Given this list of marker genes Sh3rf3, Stox2, Pik3r3, Zfp518a, Tnrc6c, Vstm2b, Magi2, Epgn, Ebf2, Usp33, Eif4g2 (eukaryotic translation initiation factor 4, gamma 2), Mphosph9 (M-phase phosphoprotein 9), Rap2c, Rnase2a, Map3k12, Marchf2, Pcdha10, Memo1, Myh11 (NCBI Gene Id 99850), Eif4a2, Mllt6, Npepl1, Fhip1a, Pik3cb, Prune2, Atp10a, Get3, Macf1, Arrdc3, Rnf167, Ephb3, Foxp1, Hbp1, Ccdc88a, Nrk, Rap1b, Adipor2, Hhip, Dsel, Sin3b, Hecw2, Kcna4, Snx17, Bcl2l11, Pcdhac2, Klhl20, Acsl1, Arc, Ark2n, Pcdha4 (protocadherin alpha 4), Dpysl5, Coq10b, Otud1, Or10d5j, Igf2r, Mycl, Cand1, Slc24a3, Phf12, Ndfip2, Wnt7b, Dnai1, Ano1, Cdk19, Bend3, Pde5a (NCBI Gene Id 242202), Rsbn1l, Tsc1, Bmpr2, Asap2, Prrt3, Pgm2l1, Slmap, Adss2, Bhlhe23, Edaradd, Fndc3a, Camsap1, Atg16l1, Tbrg4, Fastk, Ppp2r3d, Wdr26, Gpr155, Atf2, Stk35, Pdf, Nbeal2, Klf13, Mtcl2, Fam83g, Hipk3, Dipk1a, Itch, Mbnl2, Skida1, Ell2, Fosl1, Tet3, Akr1c14, Zfp91, Fras1, Rap1a (NCBI Gene Id 99734), Rhob, Adgrl2, Rnf216 (NCBI Gene Id 97262, ring finger protein 216), Rimkla, Tbc1d12, Srsf6, Ankrd29, Prickle2, Zfp563, Cast, Spryd3, Slc35f1, Ccm2, Cnot6l, Pcdha7, Ttc9, C87436, Prr5l, Fbxo8, Adamts7, Mef2a (myocyte enhancer factor 2A), Rfx4, Skil, Smarca2, Pcdhac1, Plaa, Sel1l3, Abhd17c, Klf10, Chl1, Fbxo32, Wdfy3, Vps37a, Kbtbd8, Impdh1 (NCBI Gene Id 320849), Spire1, Usp32, Txlng, Eeig1, Tnfaip3, Fut9, Sybu, Hic1, Ino80, Ube2d3, Cntfr, Klhl42, Mapk1, Rufy3, Gigyf1, Zfp965, Clip1, Pmepa1, Tab3, Atxn1, Abca1, Prkaa1, Phf13, Atxn7, Gtf2a1, Ccnl1, B4galt5, Sipa1l1, Pcdha9, Mbd6, Ddx3x, Gpcpd1 (glycerophosphocholine phosphodiesterase 1), Zfp973, Pcdha8, Sbf2, Wasl, Tshz3, Tgif1, Sdc1, Rnf11, Vps4b (vacuolar protein sorting 4B), Cnot4, Zdhhc18, Grsf1, Dtna, Gm11437, Fam83d, Trim33, Mastl, Arap2, Tfcp2l1, Phtf2, Mapk6, Zbtb10 (zinc finger and BTB domain containing 10), Pdik1l, Qki, Ddx3y, Pou4f1, Zfp827, Sgk1 (NCBI Gene Id 20393, serum/glucocorticoid regulated kinase 1), Zmynd11, Agbl3, Cnksr2 (NCBI Gene Id 245684), Med26, Mdm4, Cacna1c, Kcne2, Slc5a7, Chic1, Ube2a, B230219D22Rik, Elovl5, Cldn34c1, Castor2, Tgm3, Zfp654, Mpped2, Fmr1, Scn1b, Mylip, Adcy7, Csmd1, Lsm12, Ankib1, Adcy1, F3, Ddhd2, Ldoc1, Arhgap11a, Cep170, Acbd5, Ccdc126 (NCBI Gene Id 58912), Garem1, Etl4, Pnrc1, Lin9, Slc4a7, Rbms3, Btf3l4, Plxnc1, Dock10, Mier3, Dnaaf9, Pcdha5, Wnk1, Miga2 (NCBI Gene Id 99073), Sowahb, Cacul1 (CDK2 associated, cullin domain 1), Med13, Gtf2h1, Mycn (NCBI Gene Id 18109), Ice2, Slc6a8, Arfip1, Hbs1l, Igfbp3, Npas3, Kpna6, Fam162a, Armc8, Plxna4, Id2, Stat2, Sema4c, Brwd3, Dnajc24 (DnaJ heat shock protein family (Hsp40) member C24), Hnrnpul2, Llgl2, Zbtb18, Lrig1, Sulf1, Zfand5, Arfgef1, Tmem47, Rbbp8, Appl1, Dock4, S1pr1, Car8, Zfp992, Patl1, Syt1, Asxl2, Vti1a, Pcdha2, Rbms1, Pknox1, Usp8, Wbp1l, Lrch1, Retreg1, Mdfic, Robo2, Dgke, Suz12, Card10, Pitx1, Bnc2, Npas2, Eogt, Shank1, Tbk1, Slc31a2 (solute carrier family 31, member 2), Ldaf1, Slc9a6, Arhgap21, Pou3f2, Siva1, Klf9, Nufip2, Raf1, Zfp521, Sox6, Mtmr10, Cblb, Lrp2, Atl2, Zfp385b, Rgl1 (NCBI Gene Id 19731), Tspan2, Taf4, Dicer1, Mb21d2, Clock, Clip4, Elmod2 (ELMO/CED-12 domain containing 2), Prdm1, Pptc7, Elavl4, Tnfrsf12a, Dlx1, Zbtb4, G3bp2, Jazf1 (JAZF zinc finger 1), Desi2, Mmgt1, Cab39, Smoc1, Adcy9, Kif3a, Arrdc4, Sebox, Smad5, Etv1, Cyb561d1, Plcb1, Rhebl1, E2f8, Dock3, Tmem250, Syt11, Pcdha11, Fam114a1, Prc1, Lonrf1, Socs1, Acadm, Mecom, Zfp609, Kcnc4, Socs3, Btaf1, Vamp3, Abr, Acsl4, Mbnl3, Kdm2a, Khdc4, Gpr137b, Otud7b, Flnc, Ppp2r5e, Tmem65, Smurf1, Enc1, Mosmo, Nr3c2, Slc9a1, Tmem64, Gulp1, Atp2c1, Pcdha1, Sephs2, 3830403N18Rik, Znrf3, Sh3d19, Pcdha12, Cdkal1, Tub, Nhsl1, Rabepk, Pak6, Spty2d1, Ivns1abp, Sec63, Cc2d1a, Cnot6, Nlk, Mfsd6, Chmp1a, Btbd7, Arhgap12, Hprt1, Crebrf, AI987944, Mctp1, Rtn1, Cul5, Cgn, B3galnt2, Igsf3, Wac, Cyp2c50, Vcf1, Chst1, Slc26a7, Psd3, Reep3, Fam43a, Itga6, St8sia3, Tm6sf1, Phlda3, Pcdha3, Zfp367, Gpr137c, Grk6, Wdr45b, Tnrc6b, Rassf2, Clvs2, Med12l, Nmt2, Relch, Kpna3, Map3k2, Ccnd2, Rab33b, Fbxo48, Epn2, Wdr44, Cdc42bpa, Rab18, Ubl3, Bet1l, Rab8b, Tnks, Zfp831 (NCBI Gene Id 100043757), Rest, Tor1b, Atxn1l, Pclo, Adrb1, Rnf111, Snx25, Zmat3, Slc35a5 (solute carrier family 35, member A5), Pcdh10 (NCBI Gene Id 76209), Pik3ca, Cltc, Ccl11, Nipa2, Rapgef2, Fam168a, Ccser2, Wdr1, Aldh3a2, Sec11a, Mical3, Kcnj2, Jade1, Mab21l2, Zfp711, Dcun1d3, 2510039O18Rik, Dmxl2, Esr1, Togaram1, Fbxl4, Cbln2, Zfyve26, Pcdha6, Emx2, Nfib, Arpp19, Xlr, Atg14, Rin2, Ppara, Fzd4, Psap, Ube2d2a, Bambi, Pcsk5, Zfp516, Nfia, Rora, Zc2hc1a, Taok1, Scd1, Nrbp1, Cbx7, Tbc1d8, here is a description of the gene set: Mouse Gene Set: MIR_19B_3P Genes predicted to be targets of miRBase v22 microRNA mmu_miR_19b_3p in miRDB v6.0 with MirTarget v4 prediction scores > 80 (high confidence targets). species: Mus musculus from publication Chen Y, Wang X (PMID 31504780)